Given this list of marker genes NANOS2, STK35, CHFR, HORMAD1, TTK, FBXO5, FBXO43, RPS6KA2, LIF, NPPC, OVOL1, KNL1, PDIK1L, DUSP1, PKMYT1, DMRT1, NPR2, RAD1, TRIP13, ZWINT, MOS, here is a description of the gene set: Any process that stops, prevents or reduces the rate or extent of progression through the meiotic cell cycle. Human Gene Set: GOBP_NEGATIVE_REGULATION_OF_MEIOTIC_CELL_CYCLE species: Homo sapiens